Given this list of marker genes Cnot2, Fbxl4, Entrep1, Metap2, Lmtk2, Zfp597, Ctnnal1, Cd68, Bid, Wtap, Serpini1, Crmp1 (NCBI Gene Id 12933), Cox7b, Slc25a27, Rsbn1, Hdac2, Ccdc116, Clcn5, Atp6v1d, Gpc2, Zbtb1, Atrx, Nod2, Celf3, Rbms1, Bpnt2, Sap18, Tdrd3, Sox9, Smad3, Slc7a14, Manba, Bend4, Ro60, Usp16, Cd36 (NCBI Gene Id 12491), Rnf34, Cep170, Smarcc1, Ubap1, Ccnd2, Aste1, Fat3, Fhip1b, Utp4, Gpcpd1, Skp2, Ahcyl1, Fgfr3, 2510009E07Rik, Pax9, Ark2n, Zbtb39, Mlf1 (NCBI Gene Id 17349), Clec4a2, Rnls, Tbcel, Vma21, Pgam1, Pja2, Arih1, Vstm2b, Kremen1, Aak1, Pcdhb9, Pak5, Trim24, Scube1, Nptn, Spats2, Rufy2, D630039A03Rik, G3bp1, Cxcl9, Rfx5, Rp1, Krtap8-1, Sv2b, here is a description of the gene set: from publication Chen Y, Wang X (PMID 31504780) Genes predicted to be targets of miRBase v22 microRNA mmu_miR_3969 in miRDB v6.0 with MirTarget v4 prediction scores > 80 (high confidence targets). Mouse Gene Set: MIR_3969 species: Mus musculus